Given this list of marker genes Gm23605, Dpp4, Gm12977, Hnrnpu, Pick1, Fh1, Gigyf2, Mir7668, Sp2, Smpd5, Rfc4, Ubap2 (ubiquitin-associated protein 2), 2900079G21Rik, Rgs16, Anp32e, Rufy2, Gm7094, Dnajc13, Zfp637, A830035A12Rik, Gm25609, Ppfibp2, Gnl3, Gins2, Ddx52, Gm24665, Iho1, Pcdhgc5, Prrc2c, Phf24 (NCBI Gene Id 97191), Enah, A730062M13Rik (NCBI Gene Id 403346), Vmn1r196, Magohb, Ube2d2a, Gm2800 (NCBI Gene Id 100040484), Gamt, Fhip2b, Bbc3, Zfp395, Mrpl4, Paics, Camsap1, Cd180, Agpat2, Cyp2b23, Rasa3, Gm22972, Evl, Vgll4, Mdfic2, Gm16084, Slc12a6, Ubxn4, Uap1l1, Gm15039, Ppp1r10, 2210417A02Rik, Fxr2, Dnajb6 (NCBI Gene Id 23950), Trpv2, Gm15901, Fgfr1, Snx1, Gm26795, Tmem265, Rora, Bag5, Gm9599, Adamts8, Gm9887, Slx4ip, Ankrd24, Gm24461, Gadd45g, Swsap1, Ndfip2, Gpr157, Cd300e, Mir376c, Gm24878, Mindy3, Zfp747l1, 9430007M09Rik, Trap1, Top3a, Mrpl28, Kcnd3os, B3gnt7, Lcn12, Ikbkg, Atp5mj, Psd, Trpm1, Ptp4a2, Tmem102, Sun1, Klk8, Mir6405, Rab11fip5, Pakap, Traj58 (T cell receptor alpha joining 58), Hsd3b7, Atp7a, Btbd18, Abo, Lrrc23, Mir770, Nsa2, Adamts2, Lrrc42, Gm12610, Ino80d, Hspd1, Psmb3, Xpr1 (NCBI Gene Id 19775), Atcay, Exoc6b, Slc2a9, Nr6a1os, P2rx7, Picalm, Egr4, Pdpr, Rsph9, Slc38a8, Fgf9, Adam32, Cd9, Gm14227 (NCBI Gene Id 668931), Cyp4f15, Foxm1, Galnt17, Xrn1, Phf12, 4930533L02Rik, Gm8444, Nhlrc3, Timm17a, Sertad1, Aff1, Zfp217, Sdf2, Rhot1, Mbtps2, Rfx2, Ushbp1 (NCBI Gene Id 75670), Or10ad1, Gm14210, Fnbp4, Mir17hg, Smarcd3, Gm4321, Rph3a, Thap6, Tet3, Gm9443, Smtn, Fam193b, Dpep2, Nhsl2, Ctbp2, Txndc9, Tgoln1, Slc1a1, Eif3d, Nudt5, Usp21, Syne2, Hormad2, Ifng, Golga5, Arl2bp, Flad1, Acyp1, Tyw1 (NCBI Gene Id 212960), Zfat, Gm6985, 4930555F03Rik, Hoxa11, Eva1b (NCBI Gene Id 74813), Gm23054, Lars1 (leucyl-tRNA synthetase 1), Phc1, Dmtn, 4932412D23Rik, Mxd3, Anapc15, Farsa, Abcf3, Gm11197, Alg11, Borcs5, Tnfaip3, Glis3, Trp53cor1, Gm15032, Dnajc11, Lbr, Kazald1, Phlpp2, Diaph1, Gm14903 (predicted gene 14903), 4930509J09Rik, Tmed2, Gm11531, Znhit3, Mgst2, Mpi, D830025C05Rik, Echs1, Gm11637, Fzd7, Rfwd3, Bola3, Tprg1l, Ogt, Cpsf6, Lrp2, Zfp512b, Ufsp2, Serping1, Hspa8, Phactr4, Grin3b, Rps12-ps7, Ccdc116 (NCBI Gene Id 76872), Ttc39c, Mfsd11, Rad1, Cep41, Gm23479, Ruvbl1, Mrps10, Zfp599, Arpp21, Ccndbp1, Cln3, Fbxl22, Fgfr2 (NCBI Gene Id 20946), Hkdc1, Plekhg5, Clec2d, Lysmd1, Sirt7, Gm23527, BC050972, Fam186b, Appl1, Tmem161a, Slc30a2, Adig, Gm4342, Slu7, Zcchc10, Ltbp3 (latent transforming growth factor beta binding protein 3), Cdk2ap1, Scn3a, Wsb1, 1700122H20Rik, Bhlhb9, Itgb1, Vpreb1a, 1700047L14Rik, Recql5, Acsbg3, Mrpl9 (mitochondrial ribosomal protein L9), Supt7l, Ptges3, Rbm33, Atrip, Pwwp3b, Gm8087, Mir1199, Phf21a, Saraf, Eva1c, Ly6g, Gm4847, Trip12, Acot11, Agps, Cers2, Zfp7, Cars2, Slc9a8, Smg5, Nudt1, Gm19261, Ube2f, Cep95, Gabra2, Cp, Fastkd5, Pomp (NCBI Gene Id 66537), Sema4d, Wnk1, Pdzd9 (PDZ domain containing 9), Terf2, Snhg14, Slc2a3, Inpp5k, Gtf2h2, Nop58, Rnf170, Parp6, Faiml, Coq10b, Cox7a1, Tbl3, Fam171b, Vwf, Hspa4, 5830487J09Rik, Tbx3os1, Abcc3 (NCBI Gene Id 76408), Gm26019 (predicted gene, 26019), Gm9496, Gak, Samsn1, Pisd-ps1, Gm12803, Parp14, Cacna2d4, Itih3 (NCBI Gene Id 16426), Acer3 (alkaline ceramidase 3), Ercc6, Ckap2, Rhbdd2, Ptpn11, Gm15266, Gtf2i, Ankrd40, Fbxl20, Mysm1 (myb-like, SWIRM and MPN domains 1), Pygb, Ppip5k2, Srebf1, Atxn1l, Gm11872, Cib1, Slc38a6, Pwwp3a, Nutm1, Uba2, Gm24978, Tet1, Atxn2, 2810407A14Rik, Tcp1, Usp14, Flvcr1, Scmh1, Celf1, Mroh1, Atp6v0a1, Oas2, Gm25526, Edrf1, Plbd2, Stradb, Mien1, Kcnv2, Pde4dip, 2410002F23Rik, Gm23090 (predicted gene, 23090), Cse1l, Rad54l, Gm25918, Gse1, Sfmbt1, Gm12340, Klhl22, 2510002D24Rik, Selenon, Ttc27, Gm5129, Tmem131l, Ubap1, Fbxo28, Gpr35, Rogdi, Fam76a, Chchd10, Gm6209, Tnrc6a, Eno4, Mcm10, Fbxo42, Lrriq1, Setd2, Taco1, Niban3, 4930568G15Rik, Hhip, 1810053B23Rik, Taar9, Gys2, Mkks, Dis3l, Gm14164, Zfa-ps, Crb2 (NCBI Gene Id 241324), Scnm1, Crppa, Tex14, Gm10157, Adat1, Kat2b, Evx1, Bex6, Rex1bd, Rpl14-ps1, Pglyrp3, Tubgcp3, Phgdh, Bckdhb, Kcnip2, Smagp, Sinhcaf, Habp2, Lonrf2, Pf4, Srsf1, Dgcr8, Gm6491, Myh14, Mthfsd, Kcnk6, Atg16l1, Zc3hc1, Mdk, Strap, Limk2, Usp1, Rnaseh2a (ribonuclease H2, large subunit), Lasp1, 1110028F18Rik, Arhgdib (Rho, GDP dissociation inhibitor beta), Ttc14, Ttc24, Gm25224, Ubxn1, Lhfpl4, Kat14, Mamstr, Gm11691, Tmem242, Runx1, Ophn1, Dync1h1, Gm9506, Plekhs1, Dnajc17, Jakmip1, Nadk2, Myo10, Hmgb1, Arfgef1, Cnppd1, Rragc, Tldc2, Ctnnal1, Oxct1as, Vapa, Nabp1, Gripap1, Defb23, Naprt, 1700023H06Rik, Lrrc75aos1, Sbno1, Cdh13, Car7, Rpl10-ps2, Fam81a, Ly6g6f, Map3k14, Ndufa12-ps, Or6c8, Rabl6, Kpna7, Spcs1, Zfp661, Hspe1, Tmem53, Mxd4, Aip, Gm8213, Gm12403, Utp25, Wsb2, Wdfy3, Olig3, Acap1, Gmcl1, Park7, Meg3, Gm12339, Hsp90ab1, Pdgfd, Lifr, Akap1, Mapkbp1, Chd8, Zmynd12, Fuca1, Gm8969, Lztr1, Mlxip, Kptn, Zfp612, Sox4, Gm5764, Pomgnt1, Leo1, Plekhm3 (NCBI Gene Id 98354), Eif5a, Gm22122, Sned1, Tnik, Brwd1, Zfp142, Gm12828, Ccdc14, Dcbld2, Btrc, Irf5, Cbfb, Gm13207, Gm24296, Ganc, Tmem248, Psmd9, Gm15610, Fbxl15, Atp6v0b, Sulf1, Axdnd1, Tmem231, Vamp1, Opcml, Gm12654, Ccdc121rt2, Nbdy, Stx18, Nfe2, Cyb5r1, Oaz2-ps, Pspn, C230071H17Rik, Zfp653, Sp1, Gm12608, Ppp4r4, Itgbl1, 2310016D23Rik, Tle2, 1700025G04Rik, Gm10532, Mzf1 (NCBI Gene Id 53862), 9530082P21Rik, Arl14ep, Kif2c, Ncoa4, Ascl4, Fmo9, C130036L24Rik, D030068K23Rik, Cltc, Tulp3, Btnl10, Gm18254, Hsf3, Ddx60, Or2c1, Phox2b, Nipbl, Gm16638, Eml6 (NCBI Gene Id 73111), Rsl24d1, Crem, Pou6f1, Pknox1, Tmco2, Plekhg1, Neil3, Altre (aging liver Treg-expressed non-protein coding RNA), Arih2, Mkln1, 4933406P04Rik, Rfx4, Rnf6, Igf1os, Mgst3, Il34, Mro (NCBI Gene Id 75061), Nvl, Snhg17, Rad51c, Mrpl30, 4930532M18Rik, Milr1, Zdhhc15, Metap2, Rab27a, Brix1, Fbrsl1, Bscl2, Lrrc9, Psma7, Gpr107, Cracr2b, Mecr, 2310011J03Rik, Lag3, Cckar, Syne4, 1700120B22Rik, Setd1a, Snrnp25, Sec24c, Ncbp1, Ak5, Mycbp2, Myo15a, A930019D19Rik, Nek9, Vps72, Nos1, Psmd7, Golga2, Gm4877, Otud4, Ift81, Fam83c, Slc43a1, Uhrf1, Mepce, A630072M18Rik (NCBI Gene Id 320770), 9330136K24Rik, Rnf4, Mef2b, Mllt11, Erg, Dazl, Gm16490, 2310010J17Rik, Arrdc3, Vwc2, Rfx7, Trim67, Myo5b, Gm15651, Plaa, Tor1aip1, Fpgs, Anapc4, Gemin2, Chtop, Rhbdl2, 5031434O11Rik, Palld, Adamts6, Mcf2l, Stox2, Gm11665, Psph, Cenpe, Bltp2, Cip2a, Usb1 (U6 snRNA biogenesis 1), Tsg101, Gm7821, Ift122, Xpnpep1, Cdr2l, Peg12 (NCBI Gene Id 27412), Vac14, Gm15066, Spin1, Zfand2a (zinc finger, AN1-type domain 2A), Gm20443, Safb2, Tpd52, Tspan17, Eif3k, 2610206C17Rik, Acat1, Azi2, Gm8849, Il23a, Ninj2, Gm25091, Cep85, Mir7069, Ect2, Rcor3, Tor1aip2, Csdc2, Borcs7, Maf, Med18, Myh13, Tram1, Pde4d, D630008O14Rik, Gm14987, Serpina10, Carhsp1, Acbd4, Or4n4, Cpsf4, Hoxa11os, Brd2, Mrps36, Txnrd1, Rai1, Vmn2r-ps111, Myo3a, Gm12464, Gbp3, Zfr, Gm16342, Ccdc191, Rptor, Babam1, Csn1s2b, Hilpda, Asl, Kcnmb4os2, Mphosph9, Gm25184, Rnpep, Slc7a7 (solute carrier family 7 (cationic amino acid transporter, y+ system), member 7), Snhg7os, Elp5, Btbd19, Luc7l3, Atp8b4, Plcxd2, Ywhae, Aspscr1, Thoc2l, Mgat5, 9430024E24Rik, Zfp36l1 (zinc finger protein 36, C3H type-like 1), Stard5, Pdcd6ip, Dhx9, Mrm2, Zbtb7a, Fam169b, Impdh1, Tmem134, Niban2, A930018P22Rik, Hapstr1, Taf1d, Eri3, Gm30648, Gfm2, Lrriq4, Nr0b2, 4930444P10Rik, B4galnt3, Ccl7, Gm37885, Hmgxb4, Tpd52l2, Igf1r, Mcph1, Lyg1, Nmnat2, Limch1, Thpo, Rpn2, Nmnat3, Kdm5a, Mettl13, Gpr68, Bcas1, Gm12886, Ddx23, Teshl, Gm23390, Acad11, Prkacb, Cfh, Pbx3, Arhgap45, Mir3099, Calcoco2, Rhod, Tigd4, Scin, Fndc11, Gm29718, Fmc1, Rab5b, Oser1, Gm42918, Phldb2, Med6, Znfx1, Mir1306, Agap3, Dlk1, 4931406C07Rik, Exo5, Rian, Rpl21, Acsbg2, Gm25261, Cnot3, C630004M23Rik, Snph, Serpinb6e, Glud1, Mir7075, Dars2, Zfp319 (NCBI Gene Id 79233), Mdn1, Mtfr1, Itgb5, Ppp1r8, Top3b, Bcl2l13, Ppp2r5c, Gm17966 (predicted gene, 17966), Zbtb11, Gatc, Gm26176, Tbx15 (NCBI Gene Id 21384), Gm12740, Csde1, Slco1c1, Zfp27, Degs2, Grb10, Capn10, Tra2a, Prim2, Gm5258, Zcrb1, Gm15895, Cxxc1, Mir6997, Ube2i, Ech1, Gm15927, Ppp4r1, Gm14175 (NCBI Gene Id 100462729), Or4k52, Elk4, Mms19, Eya3, Snora17, Nfxl1, Ctxnd2, Tspyl2, Misp, Mvd, Gm13561, Gm23202, Misp3, Isca1, Dynll2, Lingo4, Gm28836, Uso1, Pde8a, Ing3, Usf2, P2rx3, Camk2d, Mmp19, Tulp1, Xab2, Rps6ka1 (ribosomal protein S6 kinase polypeptide 1), Tm4sf5, Cfap47, Sag, Znrf1, 9430015G10Rik, Prpf19, AA986860, Rbm47, Pcdhga8, Shbg (NCBI Gene Id 20415), Gm12924, Islr, Sin3b, Gm11452, Arpc5l, Sergef, Il17rc, Satb2, Hoxa7 (homeobox A7), Ngb, 2610204G07Rik, Galnt1, Tcf4, Ralgps2, Gpr84, Or6n1, Ift140, Hes1, Tbrg4, Rbm25, Shmt1, Uba5, Chd2, Itga9, Gm24400, Sf3a3, 9330162B11Rik, Gm8186, Tatdn2, Homer1, Tns3, Tpk1, Gm11444, Lbhd1, Tmcc1, Rcan2, Haus5, 4930556N13Rik, Wfs1, Lsm10, Hbp1, Qtrt2, Bmx, Mir3618 (microRNA 3618), Ikzf3, Zhx3, Ldha, Nrbp1, Gm6096, Oplah, Ptbp1, Slc9b2, H2-M5, Kdm5c, Gm20404, Smg6, Mrpl18, Manba, Usf1, Wdr75, Lrsam1, Ube2h, Dlgap5, Gga2, Reps1, Ppip5k1, Scube3, Kctd3, Tagln2, Pdlim1, Prpf38b (NCBI Gene Id 99795), Rtl5, Slx4, Gm22272, Dnaaf9, Ccna2, Cyp4a28-ps, Fam241b, Smpd2, Nfat5 (NCBI Gene Id 54446), here is a description of the gene set: from publication Yevshin I, Sharipov R, Kolmykov S, Kondrakhin Y, Kolpakov F (PMID 30445619) Mouse Gene Set: ZFP935_TARGET_GENES studied in species Mus musculus